The following is a description of a gene set: The removal of a glutamate residue from a protein. Glutamate residues in proteins can be gene-encoded, or added as side chains during the protein modification process of polyglutamylation. studied in species Homo sapiens Human Gene Set: GOBP_PROTEIN_DEGLUTAMYLATION, and this is the list of marker genes: AGBL5, AGBL4, AGBL2, FOLH1, AGBL3, AGBL1, FOLH1B, AGTPBP1